The following is a description of a gene set: T cells develop in the thymus and are critical for adaptive immunity. Natural killer (NK) lymphocytes constitute an essential component of the innate immune system in tumor surveillance, reproduction, and defense against microbes and viruses. Here, we show that the transcription factor Bcl11b was expressed in all T cell compartments and was indispensable for T lineage development. When Bcl11b was deleted, T cells from all developmental stages acquired NK cell properties and concomitantly lost or decreased T cell-associated gene expression. These induced T-to-natural killer (ITNK) cells, which were morphologically and genetically similar to conventional NK cells, killed tumor cells in vitro, and effectively prevented tumor metastasis in vivo. Therefore, ITNKs may represent a new cell source for cell-based therapies. Genes down-regulated in ITNK cells (T-lymphocyte progenitors (DN3 cells) reprogrammed to natural killer (NK) cells by ablation of BCL11B gene), compared to the parental DN3 cells. from publication Li P, Burke S, Wang J, Chen X, Ortiz M, Lee SC, Lu D, Campos L, Goulding D, Ng BL, Dougan G, Huntly B, Gottgens B, Jenkins NA, Copeland NG, Colucci F, Liu P (PMID 20538915) Human Gene Set: LI_INDUCED_T_TO_NATURAL_KILLER_DN studied in species Mus musculus, and this is the list of marker genes: FAM169BP, RMND5A, SOX4, NT5DC2, N4BP2L1, BGN, CD3D, TDRP, TRIB2, C3, LMAN2L, RGL2, MAPK1, INAFM2 (NCBI Gene Id 100505573), GLDC, ACVR2B, FBP1, SLF2, STK4, DTX1, CTSE, TTC3, TPCN1, ADGRE5, PRKCD, NAXD, CD6, H19, ITPR2 (NCBI Gene Id 3709), RPS6KL1, PLD4, CENPV, ALDH2, ACTN1, BRD3, DGKA, KLHL24, ABHD8, ZER1, SNX30, C17orf67, CCL15, COX6A2, PDXP, SH2D1A, MARCKS, PDK1, PRELP, PDLIM4, NOTCH3, NIPBL, SLC5A9 (solute carrier family 5 member 9), MMP2, ACSS1, TXNIP (NCBI Gene Id 10628), NISCH, CD27, LOX, XRCC6, PITPNM2, ALKBH1, COL6A1, NAV1, SLA, H3-3B, SETD1B, TCF7, PPARGC1B, SATB1, TAPT1, NCK2, LLGL1, POU6F1, FAM78A, ILVBL, TMEM121, SLC29A1, ANP32E, STRBP, ACTA2, RAPGEF3, MSH6, COL5A1, OLFML3 (NCBI Gene Id 56944), AQP11, TRBV30, DNTT (DNA nucleotidylexotransferase), FYB1, CRYL1, CD81, CDCA7, TBXA2R, ART4, DAP3, IGIP, CTLA4, PLEKHG2, ENDOU, TACC1, RNPEPL1, ETS1, RHNO1, ZNF260, IL17RB, RGCC, LY6D, BCL7A, TSPAN32, MIB2, DPP4, EBF3, GPR83, ETS2, PARD6G, CD2, MTF2, CXCL12, SNAI3, SLC16A5, PRKCB, GFI1, BCL11B, RAMP1, CELF2, HDAC7, CHCHD3, RRP12, IGF1R, HIBADH, ARHGAP15, TRIM28, ST6GAL1, KMT2A (NCBI Gene Id 79951), TPST1, PPP1R1C, EPHX1, TMEM108, FRAT2